Given this list of marker genes Srsf1, Swi5, Cst3, Ost4, C1qbp (complement component 1, q subcomponent binding protein), Nrros, Pkm, Hspe1, Bax, Hnrnpu, Mrps28, Cycs, Mdn1, Arsb, Pdia6, Mrto4, Gar1, Fasn, Septin3, Mcm2, Ranbp1, Cd207, Srsf6, Nop56, Polr2f, Samd1, Actr3, Hnrnpab, Ccnd1, Fzd1, Cd82, Sod2, Fkbp4, Manf, Zfp710, Calm1, Zfp366, Cdca7, Mogs, Nop58, P2ry6, Nme1, Hsp90aa1, Mybbp1a, Calr, Eef1e1, Cacybp, Hspa4, Ldha, Lcp1, Ybx3, Dynll1, Eif4e, Ctsz, Ydjc, Bri3bp, Lpcat1, Ftsj3, Prmt1, Rpn1, Eif5a, Ddx21, Srm, Nolc1, Hspa8 (heat shock protein 8), Tuba1b, Akt1, Ywhag, Myl12a (myosin, light chain 12A, regulatory, non-sarcomeric), Scd2, Srsf2 (serine and arginine-rich splicing factor 2), Srsf7, Serp1, Snx3, Tgfbi, Id2, Cd53, Srsf9, Ndufab1, Atp1a1, G3bp1, Lman2, Pfn1, Anxa2, Sdad1 (SDA1 domain containing 1), Ewsr1, Ppp1r14b, Hspd1, Irf5 (interferon regulatory factor 5), Itgal, Oxct1, Tagln2, Mdh2, Naaa, Cbfb, Anp32b, Hnrnpa2b1, Cfl1, Set, Snrpd1, Tap2, Ran, Nsmce3, Fkbp2, Fkbp1a, Hspa5, H2-DMb1, Hsp90b1, Ppa1, Ece1, Creld2, here is a description of the gene set: from publication Cui A, Huang T, Li S, Ma A, Pérez JL, Sander C, Keskin DB, Wu CJ, Fraenkel E, Hacohen N (PMID 38057668) Cytokines mediate cell-cell communication in the immune system and represent important therapeutic targets. A myriad of studies have highlighted their central role in immune function, yet we lack a global view of the cellular responses of each immune cell type to each cytokine. To address this gap, the authors created the Immune Dictionary, a compendium of single-cell transcriptomic profiles of more than 17 immune cell types in response to each of 86 cytokines (>1,400 cytokine-cell type combinations) in mouse lymph nodes in vivo. A cytokine-centric view of the dictionary revealed that most cytokines induce highly cell-type-specific responses. For example, the inflammatory cytokine interleukin-1β induces distinct gene programmes in almost every cell type. A cell-type-centric view of the dictionary identified more than 66 cytokine-driven cellular polarization states across immune cell types, including previously uncharacterized states such as an interleukin-18-induced polyfunctional natural killer cell state. Genes positively differentially expressed in cell type: cDC1 (conventional dendritic cell type 1) upon treatment with cytokine: FLT3L in mouse lymph nodes in vivo. Mouse Gene Set: CUI_CDC1_FLT3L_RESPONSE_UP species: Mus musculus